The following is a description of a gene set: Genes up-regulated in peripheral blood mononuclear cell stimulated vs unstimulated in infants (9m) (infant) after exposure to Prevnar (USA), time point 9M from publication van den Biggelaar AH, Pomat W, Bosco A, Phuanukoonnon S, Devitt CJ, Nadal-Sims MA, Siba PM, Richmond PC, Lehmann D, Holt PG (PMID 21645573) Concerns about the risk of inducing immune deviation-associated neonatal tolerance as described in mice have restricted the widespread adoption of neonatal vaccination. The aim of this study was to demonstrate the immunological feasibility of neonatal pneumococcal conjugate vaccination (PCV) which could potentially protect high-risk infants in resource poor countries against severe pneumococcal disease and mortality in the early critical period of life. Papua New Guinean infants were randomized to be vaccinated with the 7-valent PCV (7vPCV) at birth, 1 and 2 months (neonatal group, n=104) or at 1, 2 and 3 months of age (infant group, n=105), or to not receive 7vPCV at all (control group, n=109). Analysis of vaccine responses at 3 and 9 months of age demonstrated persistently higher type-1 (IFN-gamma) and type-2 (IL-5 and IL-13) T-cell responses to the protein carrier CRM(197) and IgG antibody titres to 7vPCV serotypes in children vaccinated with 7vPCV according to either schedule as compared to unvaccinated children. In a comprehensive immuno-phenotypic analysis at 9 months of age, no differences in the quantity or quality of vaccine-specific T cell memory responses were found between neonatal vaccinations versus children given their first PCV dose at one month. Hospitalization rates in the first month of life did not differ between children vaccinated with PCV at birth or not. These findings demonstrate that neonatal 7vPCV vaccination is safe and not associated with immunological tolerance. Neonatal immunisation schedules should therefore be considered in high-risk areas where this may result in improved vaccine coverage and the earliest possible protection against pneumococcal disease and death. Human Gene Set: VAN_DEN_BIGGELAAR_PBMC_PREVNAR_9MO_INFANT_STIMULATED_VS_UNSTIMULATED_9MO_UP studied in species Homo sapiens, and this is the list of marker genes: CDC25A, KIF14, E2F8, IL17F, CISH, H4C13, ESPL1, FGL2, CXCL9, CDC20, TEDC2, E2F7, H4C6, CSF2, H3C10, MCM10, DUX4L9, H3C7, CENPF, SLC27A2, DTL, MLC1, CLSPN, PBK, GZMA, LIF, CD274, ZBED2, OSM, GBP5, CCNA2, NCAPG, MMP12 (NCBI Gene Id 4321), AURKB, MKI67, FAM90A1, KIF18A, CENPE, CTSW, PRR11, H2BC14, H3C2, GZMB, H4C9, H3C12, SERPING1, PCDHB2, H2AC13, SKA3, IL17RB, HTR1A, CCNB2, AQP7, CCNB1, ASPM, H2AC16, DEPDC1B, TICRR, ZBTB32, UBE2C, PHF1, TNFSF4, SIX1, KIF4A, H2AC4, ORC1, GBP4, ELOVL6, NCAPH, DLGAP5, ANLN, SHC4, EXO1, SKA1, TRIP13, IL18R1, H2BC11, KNL1, GTSE1, H2AC21 (H2A clustered histone 21), IL12RB2, KIF23, TYMS, BIRC5, USP17L2, PRAMEF8 (PRAME family member 8), MCM4, TPX2, CKAP2L, H3C14, NEIL3, BUB1, RAD51, PLK1, GBP6, CHEK1, IL2RA, CEP55, APOL4 (NCBI Gene Id 80832), LTA, CDCA2 (cell division cycle associated 2), H2BC15, IFNG, BUB1B, HJURP, KIF11, RAB19, SSX4, IL3, CIT, MELK, SPC25, PRC1, IL9, IL13, CHAF1B, EEF2KMT, IL5, IDI2, H2AC14, FOXM1, ESCO2, TOP2A, WIPF2, RRM2, TK1, KIF2C